The following is a description of a gene set: from publication Xie X, Lu J, Kulbokas EJ, Golub TR, Mootha V, Lindblad-Toh K, Lander ES, Kellis M (PMID 15735639) studied in species Homo sapiens Genes having at least one occurrence of the highly conserved motif M115 YRTCANNRCGC in the regions spanning 4 kb centered on their transcription starting sites. The motif does not match any known transcription factor binding site. Comprehensive identification of all functional elements encoded in the human genome is a fundamental need in biomedical research. Here, we present a comparative analysis of the human, mouse, rat and dog genomes to create a systematic catalogue of common regulatory motifs in promoters and 3' untranslated regions (3' UTRs). The promoter analysis yields 174 candidate motifs, including most previously known transcription-factor binding sites and 105 new motifs. The 3'-UTR analysis yields 106 motifs likely to be involved in post-transcriptional regulation. Nearly one-half are associated with microRNAs (miRNAs), leading to the discovery of many new miRNA genes and their likely target genes. Our results suggest that previous estimates of the number of human miRNA genes were low, and that miRNAs regulate at least 20% of human genes. The overall results provide a systematic view of gene regulation in the human, which will be refined as additional mammalian genomes become available. Human Gene Set: YRTCANNRCGC_UNKNOWN, and this is the list of marker genes: TSC22D2, PTPN2, DHX40, FOXP2, KLHL34, UBE2S, ERC1, LEMD2, MMD, MIR22HG, CDKAL1, PFKFB3, PITPNB, SLC25A12, GNAO1, SRRM2, ICE2, NDEL1, RNF38, GPM6B, PARD6A (NCBI Gene Id 50855), FLNC, PPHLN1, MAML3, SLC25A28, XRCC6, DNAJA2, GRM7, STYX, CPZ, NARS2, SULT4A1, UCHL1, PELP1, SUV39H2, RASGRF1, ZBTB37, APPBP2, NCDN, ZFAND5 (zinc finger AN1-type containing 5), VGLL2, PITPNM1, TRIM46, TACC1, TMEM165, ZCRB1, PDPR, DPYSL2, NCAM1, KRTCAP2, SMARCAD1 (SWI/SNF-related, matrix-associated actin-dependent regulator of chromatin, subfamily a, containing DEAD/H box 1), WDR81, BAHD1 (bromo adjacent homology domain containing 1, NCBI Gene Id 22893), MLEC, PPP2CA, OSR1, ARIH1, CCDC25, GNB1, ELOVL5, UBE2H, SLC6A15, FAM98B, NR2E1